The following is a description of a gene set: species: Homo sapiens BACKGROUND: Dendritic cells (DC) play a central role in primary immune responses and become potent stimulators of the adaptive immune response after undergoing the critical process of maturation. Understanding the dynamics of DC maturation would provide key insights into this important process. Time course microarray experiments can provide unique insights into DC maturation dynamics. Replicate experiments are necessary to address the issues of experimental and biological variability. Statistical methods and averaging are often used to identify significant signals. Here a novel strategy for filtering of replicate time course microarray data, which identifies consistent signals between the replicates, is presented and applied to a DC time course microarray experiment. RESULTS: The temporal dynamics of DC maturation were studied by stimulating DC with poly(I:C) and following gene expression at 5 time points from 1 to 24 hours. The novel filtering strategy uses standard statistical and fold change techniques, along with the consistency of replicate temporal profiles, to identify those differentially expressed genes that were consistent in two biological replicate experiments. To address the issue of cluster reproducibility a consensus clustering method, which identifies clusters of genes whose expression varies consistently between replicates, was also developed and applied. Analysis of the resulting clusters revealed many known and novel characteristics of DC maturation, such as the up-regulation of specific immune response pathways. Intriguingly, more genes were down-regulated than up-regulated. Results identify a more comprehensive program of down-regulation, including many genes involved in protein synthesis, metabolism, and housekeeping needed for maintenance of cellular integrity and metabolism. CONCLUSIONS: The new filtering strategy emphasizes the importance of consistent and reproducible results when analyzing microarray data and utilizes consistency between replicate experiments as a criterion in both feature selection and clustering, without averaging or otherwise combining replicate data. Observation of a significant down-regulation program during DC maturation indicates that DC are preparing for cell death and provides a path to better understand the process. This new filtering strategy can be adapted for use in analyzing other large-scale time course data sets with replicates. Genes down-regulated in bone marrow-derived dendritic cellstreated by poly(IC): 3h versus 12h. Human Gene Set: GSE21033_3H_VS_12H_POLYIC_STIM_DC_DN from publication Olex AL, Hiltbold EM, Leng X, Fetrow JS (PMID 20682054), and this is the list of marker genes: TM7SF2, ADAM2, CATSPERB, IDH2, CASP4, PRELP, MIB2, ALX1, MARCHF9, TMPRSS6, GALNT10, STAC, SMIM31 (NCBI Gene Id 100509060), RGS9BP, LHX4, MAP3K10, SLC38A8, SPHKAP, PAOX, RNF187, EFNB3, PAWR, SLC26A8, GRAMD2A, GET4, POLD4, RASA4 (RAS p21 protein activator 4), ENAH, RSPH9, DPY19L2, ADRA1A, SPATA31F3, NAT14, PIAS4, KLHL40, SLCO3A1, KRT32, SLC25A14, GABRA1 (NCBI Gene Id 2554), VWA5B2, DSC3, GUCY1A1, MIR182, GPR141 (G protein-coupled receptor 141), DNAI7, ZFP36, SLC16A12, SYT15, KRT222, ETV4, MMP3, CACNA1B, ZNF250, MIR299, HEXIM2, CYP2W1, AOC1, SAMD3, ANK2, STEAP4, KCNQ4, PITPNM1, MAD1L1, OLFML3 (olfactomedin like 3), CLDN4, DHRS3, BLVRB, NPC1L1, AFM, IGF1R, SLCO4A1, ASB17, HSPA1A, TMEM25, TMEM8B, CPLX4, FOXR2, MMP15 (matrix metallopeptidase 15), CSRNP3, TDRD5 (tudor domain containing 5), MPP3, TMEM41A, EDF1, PI15, ZIC3, TRAFD1, ROBO1, ZFYVE27, IGFBP1, POU4F3, TMEM63C (transmembrane protein 63C), PPT2, PDCD1, TSPAN18, TMEM214, PDGFB, CYP11B1, OPALIN, IL1RAPL1, ABCG4, XK, RNF135, CACNB1, PLXND1, UGT3A1 (NCBI Gene Id 133688), C5AR1, ODF4, PAQR8, CASTOR1, DSG2, CD177, LCE3B, CYP2G1P, MRPL17, TTLL11, DUSP18, MRAP2, LMLN, TCF3, TGFB1I1, HRAS, PRRG2, FGD5, TCAF1, EML3, PILRA, SBSN, TM7SF3, RBMY1A1 (RNA binding motif protein Y-linked family 1 member A1), RASGRP3 (RAS guanyl releasing protein 3), ZFP41, LRAT (lecithin retinol acyltransferase), PCBD2, KDM4A, MRPS11, STXBP5L, SIK1, PMP2, MYL10, FGF7, SYNPR, NTSR2 (neurotensin receptor 2), CEBPD, RNF141 (ring finger protein 141), H2AC1, JAML